Given this list of marker genes GNG4, CFL2, GNG10, GNB3, GNG13, GNG12, GNG7, RAC1, LIMK1, GNB5, RAC2, GNB1, RAC3, GNG8, GNB2, CFL1, GNG2, CXCL12, GNG11 (NCBI Gene Id 2791), PAK1, GNGT1, GNGT2, GNG3, CXCR4, GNG5, GNB4, here is a description of the gene set: Human Gene Set: KEGG_MEDICUS_REFERENCE_CXCR4_GNB_G_RAC_SIGNALING_PATHWAY CXCR4-GNB/G-RAC signaling pathway. Pathway ID: N00433. Pathway type: Reference. Pathway class: nt06161 Human immunodeficiency virus 1 (HIV-1). Pathway Definition from KEGG: CXCL12 -> CXCR4 -> GNB/G -> RAC -> PAK1 -> LIMK1 -> CFL species: Homo sapiens